The following is a description of a gene set: species: Mus musculus Mouse Gene Set: GOBP_RESPONSE_TO_HEAT Any process that results in a change in state or activity of a cell or an organism (in terms of movement, secretion, enzyme production, gene expression, etc.) as a result of a heat stimulus, a temperature stimulus above the optimal temperature for that organism., and this is the list of marker genes: Hsbp1, Eif2b3, Rbbp7, Trp53inp1, Hsbp1l1, Cntnap2, Atxn3, Hsp90aa1, Igf1, Rasa3, Hspa1a, Lrp11, Hspb6, Cryaa, Zfp976, Trpa1, Hspa2, Asic3, Slu7, Slc52a3, Vcp, Nf1, Bag3, Slco1b2, Casq1, Hpcal4, Ywhae, Cryab, Stac, Cetn1, Map2k7, Dnaja4, Clpb, Cdkn1a (cyclin dependent kinase inhibitor 1A), Eef1d, Akt1, Dnajb1, Hspa8, Scara5 (scavenger receptor class A, member 5, NCBI Gene Id 74378), Trpm2, Dnaja1, Calca, Prkaca, Trpv1, Pirt, Eif2s1, Htra2, Sumo1, Myof, Daxx, Eif2b2, Ier5 (immediate early response 5), Dhx36, Scn2b (sodium channel, voltage-gated, type II, beta), Hmox1, Mtor (mechanistic target of rapamycin kinase), Hikeshi, Pmp22, Chordc1, Arpp21, Il1r1, Fgf1, Hspb1, Tpr (NCBI Gene Id 74816), Eif2b4, P2rx3 (purinergic receptor P2X, ligand-gated ion channel, 3), Pdcl3, Dhx9, Osm, Ptgs2, Crnn, Dnaja2, Pdcd6, Hspb2, Tfec, Hspa1b, Hsf3, Ckm, St8sia1, Sod1, Il1a, Hsf1, Irak1, Ano1, Hsp90ab1, Mill1, Gclc, Psip1, Lyn, Xylt1, Tcim, Eif2b5, Scn11a (sodium channel, voltage-gated, type XI, alpha), Nos1, Eif2b1, Trpv4, Dnaja3, Mapt